The following is a description of a gene set: species: Homo sapiens Microglial cells are resident macrophages in the central nervous system (CNS) and play a pivotal role in the innate and adaptive immune responses against microbial infections. The immune functions of microglia are regulated by a milieu of cytokines including interferon (IFN)-gamma. We here performed a series of experiments to acertain the transcriptional profile of human fetal microglial cells at 1, 6, and 24 h after IFN-gamma treatment. Primary human microglial cells were either untreated or treated with 200u/ml IFN-gamma. Affymetrix U133A chips were utilized. Four different tissue samples (B18, O, W, and Y20) were analyzed at the three time points. Human Gene Set: GSE1432_1H_VS_24H_IFNG_MICROGLIA_UP Genes up-regulated in comparison of microglia cells 1 h after stimulation with IFNG versus microglia cells 24 h after the stimulation. from publication Rock RB, Hu S, Deshpande A, Munir S, May BJ, Baker CA, Peterson PK, Kapur V (PMID 16163375), and this is the list of marker genes: RNF122, RPS6KB1, GABARAPL1, MAP4K4, CRKL, RCE1, GAPDH (glyceraldehyde-3-phosphate dehydrogenase), IFNA16, FOLR2, NELFE, IL1R2, SGSM2, KIDINS220, STIL, CEP68, IL7R, ITPKB, OLR1, PPM1D, SSH1, IVNS1ABP, SDS (serine dehydratase), PRPF18, COX7A1, RIMS2, IRS4, MSRA, SDC2 (syndecan 2), DNMBP, FOXO1, PFDN1, RBBP8, FOSL2, ALPK3, GADD45B, MED27, OPN3, HTRA1, ZMIZ1, DNAJB5 (NCBI Gene Id 25822), MMP19, HBEGF, GPNMB, CASP9 (NCBI Gene Id 842), SKI, PHF10, PMP22, CD9, IFNGR1, MAMLD1, ANXA2, VIM, VDR, APH1B, APBB3, TIPARP, CSF2RA, ALOX12, JARID2, PPP4R1, HECA, GPR183, WIPI1, GAS8-AS1, CXCR4, RGS16, NFIL3, SLC35D1, VEGFA, CD14, ABHD5, ITM2C, TRIB1, LMNA, IL1R1, SLC7A8, TGFB3, SEL1L (NCBI Gene Id 6400), AATK, SLC19A2, EPAS1, GRIN2C, FKBP4, SNCA, CD163, AVPI1, SLC4A7 (NCBI Gene Id 9497), NCS1, INPP5A, INPP1, RNASE4, MACROD1, DAB2 (NCBI Gene Id 1601), NOTCH3, OAT, CTIF, PAPSS2, GAB2, MMP2, COL6A1, PLXND1, SCAMP1, NBPF10, PSD4, ANG, MMD, ANXA6, SOCS3, UBC, BNIP3L, CERK, HSPB8, CRADD, TLCD3A, SERINC5, NUP98, RTN3, HS3ST2, SATB1, SCD, ZMYM2, MAPK13, PDE4D, CELSR1, METTL22, PDE3B, CTDSPL, PGM1, TAL1, CYP2C18, NR4A3, PFDN5, GFOD1, USP47, ACOT11, CRB1, BRD8, TYMS, PID1 (NCBI Gene Id 55022), PITPNC1, PEX16 (peroxisomal biogenesis factor 16, NCBI Gene Id 9409), REXO2, PDGFC, IRGQ, RPS6, LGALS1, CISH, LPXN, SLC16A10, CDC37L1, PRPF4, LTBP2, RPS5, HS3ST1, SHB, CERS2, ANXA5, SLA, RABIF, SGPL1, STAB1, PKIG, TGFA, ANXA2P2, NUAK1, PTH2R, PDE4A, MPO, HIF1A, UNC13B, CLN8, PHF24, MLF1, XYLT1, RCOR1, WIPF2, ARL4C, GADD45G, REV3L, C5AR1 (complement C5a receptor 1), GSTM3, TAAR2, PLK2, TRAK1, PAQR5, NHERF1, SEMA6B, HGSNAT, TNFRSF21, ZNF8, CADM4, MAOA, AGPAT4, THBD, SLC16A6, RAMP1, FLNA, COX4I1, CHMP1B (charged multivesicular body protein 1B), GNG12